Given this list of marker genes Naa10, Naa16, Naa15, Naa12, Naa50, Naa11, here is a description of the gene set: Mouse Gene Set: GOCC_NATA_COMPLEX species: Mus musculus A conserved complex that catalyzes the transfer of an acetyl group to an N-terminal Ser, Ala, Gly, or Thr residue of a protein acceptor molecule. In Saccharomyces the complex includes Nat1p and Ard1p, and may contain additional proteins.